The following is a description of a gene set: from publication Bild AH, Yao G, Chang JT, Wang Q, Potti A, Chasse D, Joshi MB, Harpole D, Lancaster JM, Berchuck A, Olson JA Jr, Marks JR, Dressman HK, West M, Nevins JR (PMID 16273092) species: Homo sapiens Human Gene Set: BILD_MYC_ONCOGENIC_SIGNATURE The development of an oncogenic state is a complex process involving the accumulation of multiple independent mutations that lead to deregulation of cell signalling pathways central to the control of cell growth and cell fate. The ability to define cancer subtypes, recurrence of disease and response to specific therapies using DNA microarray-based gene expression signatures has been demonstrated in multiple studies. Various studies have also demonstrated the potential for using gene expression profiles for the analysis of oncogenic pathways. Here we show that gene expression signatures can be identified that reflect the activation status of several oncogenic pathways. When evaluated in several large collections of human cancers, these gene expression signatures identify patterns of pathway deregulation in tumours and clinically relevant associations with disease outcomes. Combining signature-based predictions across several pathways identifies coordinated patterns of pathway deregulation that distinguish between specific cancers and tumour subtypes. Clustering tumours based on pathway signatures further defines prognosis in respective patient subsets, demonstrating that patterns of oncogenic pathway deregulation underlie the development of the oncogenic phenotype and reflect the biology and outcome of specific cancers. Predictions of pathway deregulation in cancer cell lines are also shown to predict the sensitivity to therapeutic agents that target components of the pathway. Linking pathway deregulation with sensitivity to therapeutics that target components of the pathway provides an opportunity to make use of these oncogenic pathway signatures to guide the use of targeted therapeutics. Genes selected in supervised analyses to discriminate cells expressing c-Myc from control cells expressing GFP., and this is the list of marker genes: RRP9, FARP1, MST1R, FCHSD1, XPO5, PDP1, NPM1, SFXN4, ABCC3, NOP2, DUSP22, HK2-DT, UBALD1, SCFD2, PHB1, SRM, NTF4, NRP1, UTP4, GPATCH4, GNL3, MAP3K6, DHRS1, DDAH2, GPD1L, ATP2B4, TMEM97, TWNK, FGD6, NLE1, RABEPK (NCBI Gene Id 10244), PMM2, CCNG2, DTX2P1-UPK3BP1-PMS2P11, WSB1, ALDH1B1, ACSS2, ALS2CL, EMP1, HS6ST2 (NCBI Gene Id 90161), ALG3, SLC6A8, AGPAT5, PNPT1, MTMR11, MON1A, MEG3, SERPINB1, IPO4 (NCBI Gene Id 79711), UBIAD1, PC, SORL1, MCRIP2, SLC29A2, TRMT1, GEMIN5, ERCC1 (ERCC excision repair 1, endonuclease non-catalytic subunit), PA2G4, PRR5, TRIOBP, LTBP2, PCYOX1L, BCS1L, NIT1, DPH1, BOP1, INTS6L, FARSA, ERBB3, ZNF667, DGKA, WDR12, BID, RUNX1, HSPD1, CCDC137, COL8A2, FARSB, SLC6A15, SESTD1, TUBA1A, OR2A4, COL5A1 (NCBI Gene Id 1289), TGM2, TCOF1, PES1, SSH3, TFB2M, SMURF1, CYTH2, ADAM8, TNFAIP2, METTL1, KCNQ5, NLRP1, DHODH, ATIC, STMN3, TINF2, UTP14C, ZBED2 (NCBI Gene Id 79413), MCOLN2, CCDC86, MYC, ABL2, PLAU, EPS8L1, DAB2, CFLAR, NOLC1, HSPA6, IRF9, HSPA1A, BMAL1 (basic helix-loop-helix ARNT like 1), NEU3, MICAL1, PAICS, LINC00173, DKC1, DDX18, PCOLCE2, PLD6, KHNYN, SLC12A8 (NCBI Gene Id 84561), PLEKHG3, PHF1, CCDC78, FGF11, ADGRF1, UTP20, SNHG16, AKAP12, MRTO4, CDK4, CDK2, AHNAK, FAM86C1P, ADISSP, SMTN, LAMC2, GPRC5A, PLEC, H2AC6, FLAD1, EXOSC5, CIART, ADAMTS15 (NCBI Gene Id 219807), MYBBP1A, BEND3, IMP4, NGFR, UTP25, PLEKHG2, FGFBP1, UBE2D4, NCL, PTRH2, RCL1, DUSP2, CDCA8, MKNK1, ERVMER34-1, NOL6, NOP56, SLITRK6, PFKM, FAM86B3P, VAMP1, SLC19A1, MEAK7, SPTAN1, RNF213, ANGEL1 (angel homolog 1), ANAPC1, CGN, NFKB2, TAF4B, DCAF4, YPEL3, RPP40, LSG1, EEF1AKMT4, FLNB, C19orf48P, RHBDF1, DDX28, DUOX1, TTLL12, COL1A1, SUPV3L1, FAM168A, LBHD1, DDX10, UTP14A, GOLGA2, KRTAP2-3, OSBP2, SORD, TGM1, VMP1, FAM193B, NUFIP1, WDR74, AIMP2, NOP16, BMAL2, KICS2, NCR3LG1